Given this list of marker genes Agl, Vldlr, Cited2, Ccng2, Maff, Fgb, Bhlhe40, Pabpc2, Sra1, here is a description of the gene set: Mouse Gene Set: GROSS_HYPOXIA_VIA_HIF1A_ONLY species: Mus musculus from publication Gross C, Dubois-Pot H, Wasylyk B (PMID 17704799) Genes uniquely up-regulated in SEND cells (skin endothelium) at hypoxia after knockdown of HIF1A by RNAi. The ternary complex factor Net/Elk3 is downregulated in hypoxia and participates in the induction by hypoxia of several genes, including c-fos, vascular endothelial growth factor and egr-1. However, the global role of Net in hypoxia remains to be elucidated. We have identified, in a large-scale analysis of RNA expression using microarrays, more than genes that are regulated by Net in hypoxia. In order to gain insights into the role of Net in hypoxia, we have analysed in parallel the genes regulated by HIF-1alpha, the classical factor involved in the response to hypoxia. We identified about genes that are regulated by HIF-1alpha in hypoxia. Surprisingly, when we compare the genes induced by hypoxia that require either Net or HIF-1alpha, the majority are the same (75%), suggesting that the functions of both factors are closely linked. Interestingly, in hypoxia, Net regulates the expression of several genes known to control HIF-1alpha stability, including PHD2, PHD3 and Siah2, suggesting that Net regulates the stability of HIF-1alpha. We found that inhibition of Net by RNAi leads to decreased HIF-1alpha expression at the protein level in hypoxia. These results indicate that Net participates in the transcriptional response to hypoxia by regulation of HIF-1alpha protein stability.